The following is a description of a gene set: Genes down-regulated in comparison of untreated CD4 T cells at 0 h versus the cells treated with IL4 and anti-IL12 at 2 h. Human Gene Set: GSE17974_CTRL_VS_ACT_IL4_AND_ANTI_IL12_2H_CD4_TCELL_DN from publication Elo LL, Järvenpää H, Tuomela S, Raghav S, Ahlfors H, Laurila K, Gupta B, Lund RJ, Tahvanainen J, Hawkins RD, Oresic M, Lähdesmäki H, Rasool O, Rao KV, Aittokallio T, Lahesmaa R (PMID 20620947) The aim of this dataset was to study in detail the transcription kinetics initiated by cytokine IL-4 in early differentiation of Th2 cells. studied in species Homo sapiens, and this is the list of marker genes: PDCD2L, HAX1, SH2D2A, ATG101, VPS35, RALA (NCBI Gene Id 5898), MFSD14B, NABP1, MED21, YWHAE, GNPNAT1, OLIG1, HSPD1, RAB1B, NLE1, HCP5, MIR17HG, DHRS7B, ZNF780A, CHAC2, SPRY1, C1GALT1C1, DLC1, GNG5, PIGV, IMP3 (NCBI Gene Id 64970), CYTIP, SPINT2, CCT4, TUT7, SLC39A8, MRPL35, TESPA1 (NCBI Gene Id 9840), PLPP1, LAMP3 (lysosomal associated membrane protein 3), COPS8, PSMD8, FBXO30, GNL2, TOLLIP, DLAT, MRPL42, NEMP1, EPC2, CHMP2A, FLT1, BYSL, RCC1L, EMP1, CSNK2B, LARP4, NUP42, MRPL17, TP53RK, INTS6L, TBL2, STX6 (NCBI Gene Id 102724791), ST8SIA4, EIF2B2, SNRNP35, MED18, FADD, EZH2, GAR1, ZNF709, TIMM8A, EEIG2, PER2, NSDHL, FAM241A, NMI, PJA1, PIGM, NR4A3, EGR1, NAA30, CDC42EP3, MRPS28, ERLIN1, SEC24A, ORMDL2, TXNDC17, MRPL20, B3GNT5 (UDP-GlcNAc:betaGal beta-1,3-N-acetylglucosaminyltransferase 5), KLF10, KCTD12, SLC17A5 (solute carrier family 17 member 5), RRAGA (NCBI Gene Id 115960), PRDX1, KCTD21, SDHAF2, CEP19, TP53BP1, SLC7A1, CCT5, TXNDC15, IMMT, RABIF, CDK4, FBXW11, RBBP8, PHLDA1, TRMT10C, CCNH, TNFSF11, NR4A1, SRSF1, TRAF3, BCOR, RASGRP3, DNAJA3, ALG2, CD200, ZPR1, SDF2, QPCT, MFAP1, ADIPOR2, GNPDA1, FASLG, RAB27A, EOMES, EMG1, SLC25A32, NCBP1, CTNNAL1, NDUFA8, C1orf216, PPIL1 (NCBI Gene Id 5482), RAB27B, GFOD1, LEO1, FAM98A, PSMB5, NUP88, GFI1, CTSL, COPS5, AARS1, MED20 (NCBI Gene Id 9477), GON7, FBXO22, PKIA (cAMP-dependent protein kinase inhibitor alpha), TTLL4, SMIM15, GPATCH4, UTP14C, EIF3J, RING1, SLC30A5, UTP18, APOL6, CCT3, ZNF230, SRP54, IL1RN (interleukin 1 receptor antagonist), DUSP14, DNAJC17, TMBIM1, ZNF470 (zinc finger protein 470), SERTAD1, NT5E (5'-nucleotidase ecto), EED, AMMECR1L, RBM28, MRPS16, MTHFD2, CRNKL1, ZNF410, GPR183, CENPBD1P, TUBD1, ZNF557, ZNF879, GBP2, RPGR, GLB1, CARS1, TEX30, SHMT2, ZNF232, SERAC1, TOP1, CYCS, TRDMT1, JMJD4, MIR3142HG, SLC26A2, NUBP1, POLR3D, DSE, EIF2B4 (eukaryotic translation initiation factor 2B subunit delta), COPB2, LINC01128, TXNRD1, ZNF234, ALG13, ARG2